The following is a description of a gene set: The beneficial effect of the selective estrogen receptor (ER) modulator tamoxifen in the treatment and prevention of breast cancer is assumed to be through its ability to antagonize the stimulatory actions of estrogen, although tamoxifen can also have some estrogen-like agonist effects. Here, we report that, in addition to these mixed agonist/antagonist actions, tamoxifen can also selectively regulate a unique set of >genes, which are minimally regulated by estradiol (E2) or raloxifene in ERalpha-positive MCF-7 human breast cancer cells. This gene regulation by tamoxifen is mediated by ERalpha and reversed by E2 or ICI 182,780. Introduction of ERbeta into MCF-7 cells reverses tamoxifen action on approximately 75% of these genes. To examine whether these genes might serve as markers of tamoxifen sensitivity and/or the development of resistance, their expression level was examined in breast cancers of women who had received adjuvant therapy with tamoxifen. High expression of two of the tamoxifen-stimulated genes, YWHAZ/14-3-3z and LOC441453, was found to correlate significantly with disease recurrence following tamoxifen treatment in women with ER-positive cancers and hence seem to be markers of a poor prognosis. Our data indicate a new dimension in tamoxifen action, involving gene expression regulation that is tamoxifen preferential, and identify genes that might serve as markers of tumor responsiveness or resistance to tamoxifen therapy. This may have a potential effect on the choice of tamoxifen versus aromatase inhibitors as adjuvant endocrine therapy. species: Homo sapiens from publication Frasor J, Chang EC, Komm B, Lin CY, Vega VB, Liu ET, Miller LD, Smeds J, Bergh J, Katzenellenbogen BS (PMID 16849584) Human Gene Set: FRASOR_TAMOXIFEN_RESPONSE_UP Genes preferentially up-regulated in MCF-7 cells (breast cancer) by tamoxifen but not by estradiol or fulvestrant (ICI 182780)., and this is the list of marker genes: YWHAZ, IER3, CDK19, SOCS1, ZNF185, RGS3, MSH2, UPF1, IL13RA1, TASOR, PKIA, SUN2, KRT13, OR7E14P, SRD5A1, TM7SF2, STAG1, FARP1, GBE1, GGA2, CPM, SLC25A1, PTPRG, PCYOX1, OAZ3, B3GNT2, KBTBD2, ADGRG1, SDC1, LSS, LTBP1, RAB30, ELF3, CDK18, WNT4, RDX, NIBAN1, SERPINA1, SHANK2, CD44, MECOM, LASP1, ETNK1, PRPS1, DAB2, BHLHE40, EFNB2, ASCL1 (achaete-scute family bHLH transcription factor 1), KLC1, CLIC3, PGRMC1